The following is a description of a gene set: from publication Müller-Tidow C, Steffen B, Cauvet T, Tickenbrock L, Ji P, Diederichs S, Sargin B, Köhler G, Stelljes M, Puccetti E, Ruthardt M, deVos S, Hiebert SW, Koeffler HP, Berdel WE, Serve H (PMID 15024077) The acute myeloid leukemia (AML)-associated translocation products AML1-ETO, PML-retinoic acid receptor alpha (RARalpha), and PLZF-RARalpha encode aberrant transcription factors. Several lines of evidence suggest similar pathogenetic mechanisms for these fusion proteins. We used high-density oligonucleotide arrays to identify shared target genes in inducibly transfected U937 cells expressing AML1-ETO, PML-RARalpha, or PLZF-RARalpha. All three fusion proteins significantly repressed the expression of genes and induced the expression of genes. Several of the regulated genes were associated with Wnt signaling. One of these, plakoglobin (gamma-catenin), was induced on the mRNA and protein level by all three fusion proteins. In addition, primary AML blasts carrying one of the fusion proteins significantly overexpressed plakoglobin. The plakoglobin promoter was cloned and shown to be induced by AML1-ETO, with promoter activation depending on the corepressor and histone deacetylase binding domains. The induction of plakoglobin by AML fusion proteins led to downstream signaling and transactivation of TCF- and LEF-dependent promoters, including the c-myc promoter, which was found to be bound by plakoglobin in vivo after AML1-ETO expression. beta-Catenin protein levels and TCF and LEF target genes such as c-myc and cyclin D1 were found to be induced by the fusion proteins. On the functional level, a dominant negative TCF inhibited colony growth of AML1-ETO-positive Kasumi cells, whereas plakoglobin transfection into myeloid 32D cells enhanced proliferation and clonal growth. Injection of plakoglobin-expressing 32D cells into syngeneic mice accelerated the development of leukemia. Transduction of plakoglobin into primitive murine hematopoietic progenitor cells preserved the immature phenotype during colony growth, suggesting enhanced self-renewal. These data provide evidence that activation of Wnt signaling is a common feature of several balanced translocations in AML. studied in species Homo sapiens Human Gene Set: MUELLER_COMMON_TARGETS_OF_AML_FUSIONS_DN Down-regulated target genes shared by acute myeloid leukemia (AML) translocation products PML RARA, AML1 ETO, and PLZF RARA., and this is the list of marker genes: HSF4, DOC2A, SSX2, STK3 (NCBI Gene Id 6788), H4C9, SH3BP2, FRMPD4 (NCBI Gene Id 9758), EZH2, CCRL2, MKNK1, ATP2B1, PCDHGB4, CXCL8, PLSCR1, CGB3, DRD4, ID2, IFI44L, CSF2, PFKFB4, DCHS1, NOP14, CCL2, SERPINF1, NOP14-AS1, SDC4, VRK2, PIM1, CACNB1, UPK2, VRK1, GTPBP1, ELF4, HNF4A